Given this list of marker genes TIAL1, AAK1, SPTB, PRUNE1, PPP2R5B (protein phosphatase 2 regulatory subunit B'beta), SDCCAG8, UGGT2, IPO7, ADO, KLHDC3, PNPLA6, TBC1D17, IRF2BP1, NTAN1, ATL2, YWHAE, MON1A, NCDN, PABIR1, DAZAP1, UBE2N (NCBI Gene Id 7334), NSD3, GSK3A, CA14 (carbonic anhydrase 14), MTR (5-methyltetrahydrofolate-homocysteine methyltransferase), CEP290, ST3GAL2, MISP, MAX, UBALD1, FEN1, CNTN6, SF3A1, MRPL24, NAPB, CCDC177, TMEM258, ZEB2 (zinc finger E-box binding homeobox 2), ZNF546, PCSK2, TSNAXIP1, KMT2D, PAK3, CLSPN (NCBI Gene Id 63967), RANBP10, ZNF420, TTLL4, TPR, FBXL19-AS1, ACBD5, MADD, SYMPK, RASSF2, ZFP28, ZNF227, FOXA3, USP48, NUTF2, MINDY1, TLE4, STMN1, AKT1S1, CAPN15 (calpain 15), GRK5, CNOT4, TMEM115, POLR1G, IFTAP, HOXD11, CSNK2B, TRUB1, GPANK1, ASXL1, INO80E, BRMS1L, EBF2, ODR4, NFATC2IP (nuclear factor of activated T cells 2 interacting protein), GPD1L, HSD3B7, DHX30, RDH12, SYT3, ZNF112, ACP6 (NCBI Gene Id 95651), PHF13, PA2G4, DPYSL5, ABCC5, FYCO1, NCLN, CLPB, FHIT, PRKCI, FNTB, ABLIM2, CACNA1G, HIRIP3, RRAS, DPF1, TLCD3B, TAFA2, SIX1, SAMD12, SLC16A4, HSPH1, ZSCAN20, GTPBP2, FES, CREBZF, RNF220, BLCAP, SP2, RPIA, CFL1, RUNX1, MEA1, ZFP1, ITPR1, here is a description of the gene set: Comprehensive identification of all functional elements encoded in the human genome is a fundamental need in biomedical research. Here, we present a comparative analysis of the human, mouse, rat and dog genomes to create a systematic catalogue of common regulatory motifs in promoters and 3' untranslated regions (3' UTRs). The promoter analysis yields 174 candidate motifs, including most previously known transcription-factor binding sites and 105 new motifs. The 3'-UTR analysis yields 106 motifs likely to be involved in post-transcriptional regulation. Nearly one-half are associated with microRNAs (miRNAs), leading to the discovery of many new miRNA genes and their likely target genes. Our results suggest that previous estimates of the number of human miRNA genes were low, and that miRNAs regulate at least 20% of human genes. The overall results provide a systematic view of gene regulation in the human, which will be refined as additional mammalian genomes become available. Human Gene Set: GGAMTNNNNNTCCY_UNKNOWN Genes having at least one occurrence of the highly conserved motif M74 GGAMTNNNNNTCCY in the regions spanning 4 kb centered on their transcription starting sites. The motif does not match any known transcription factor binding site. species: Homo sapiens from publication Xie X, Lu J, Kulbokas EJ, Golub TR, Mootha V, Lindblad-Toh K, Lander ES, Kellis M (PMID 15735639)